The following is a description of a gene set: Lysosomal degradation of glycoproteins is part of the cellular homeostasis of glycosylation. The steps outlined below describe the degradation of chondroitin sulfate and dermatan sulfate. Complete degradation of glycoproteins is required to avoid build up of glycosaminoglycan fragments which can cause lysosomal storage diseases. Complete degradation steps are not shown as they are repetitions of the main ones described here. The proteolysis of the core protein of the glycoprotein is not shown here. studied in species Homo sapiens part of: Chondroitin sulfate/dermatan sulfate metabolism Reactome Pathway: CS/DS degradation, and this is the list of marker genes: GLB1, HYAL4, ARSB, BGN, GLB1L, GUSB, HEXA (NCBI Gene Id 3073), HYAL1, IDS (iduronate 2-sulfatase), BCAN, CSPG5, HYAL3, IDUA, HEXB, GLB1L3, NCAN, VCAN, GLB1L2, CSPG4, DCN